Given this list of marker genes Aanat, Ddc, Tph1, here is a description of the gene set: Reactome Pathway: Serotonin and melatonin biosynthesis This event has been computationally inferred from an event that has been demonstrated in another species.<p>The inference is based on the homology mapping from PANTHER. Briefly, reactions for which all involved PhysicalEntities (in input, output and catalyst) have a mapped orthologue/paralogue (for complexes at least 75% of components must have a mapping) are inferred to the other species. electronically inferred by orthology from the curated human pathway studied in species Mus musculus part of: Metabolism of amine-derived hormones